The following is a description of a gene set: Mouse Gene Set: GOBP_NEGATIVE_REGULATION_OF_EXTRINSIC_APOPTOTIC_SIGNALING_PATHWAY_VIA_DEATH_DOMAIN_RECEPTORS studied in species Mus musculus Any process that stops, prevents or reduces the frequency, rate or extent of extrinsic apoptotic signaling pathway via death domain receptors., and this is the list of marker genes: Fga, Icam1, D1Pas1, Grina, Gsk3b, Raf1, Brca1, Ddx3x, Bcl2l1, Tnfrsf22, Fgg, Tnfrsf23, Hmox1, Faim, Itprip, Fgb, Hgf, Faiml, Rffl, Cflar, Faim2, Nol3, Rnf34, Pea15a, Sfrp2, Tmbim1, Hmgb2, Tnfaip3, Gpx1, Serpine1, Park7